The following is a description of a gene set: Mouse Gene Set: chr2G3 studied in species Mus musculus, and this is the list of marker genes: E130215H24Rik, Rbck1, AA387200, Gm14133, 6820408C15Rik, Thbd, Gm14154, Defb20 (NCBI Gene Id 319579), Gm14150, Sdcbp2, Gm14127, Gm10770, Cstdc1, Rps15a-ps7, Cst9, Zfp937, Gm23005, Gm14129, Cstl1, Nrsn2, Mir1953, Gm27343, Gm24221, Gm10750, Gm14156, Gm22187, Tcf15, Defb22, Scrt2, Apmap, Cd93, Cst13, Gins1, 3300002I08Rik, Gm23598, Sox12, Syndig1, Rspo4 (NCBI Gene Id 77217), 4930442J19Rik (NCBI Gene Id 74660), Fkbp1a, Srxn1, Gm14151, 4921509C19Rik, 9030622O22Rik, Defb29, Vsx1, Zcchc3, Fndc10l, Tbc1d20, Gm14165, Nxt1, Cst8, C530025M09Rik, Rad21l, Gm14153, Abhd12 (abhydrolase domain containing 12), Pygb, Gm14130 (predicted gene 14130), Tmem74b (NCBI Gene Id 71379), Zfp1005, Cst3, Csnk2a1, Gm14167, Snph, Gm14152, Gm14147, Cst5, Gm14125, Fam110a, Zfp345 (zinc finger protein 345), Gm14143, Gm14149, Defb23, Gm14108, Entpd6, Cst12, Zfp442, Zfp1004, Trib3, Gm14135, Tmem74bos (NCBI Gene Id 228767), Gm14140, Gm14121, Ninl, Gm14148, Acss1, Cst7, Zfp1001, Sstr4, Cst11, Gzf1, Slc52a3, Gm14141, Nsfl1c, Gm14128, Gm14164, 4930556L07Rik, Psmf1, Gm14122, Defb26, Gm14123, Gm14144, Angpt4, Gm1330, Gm25866, Foxa2, Defb28, Zfp120, Napb, Gm14132, Cstdc2, Nanp